Given this list of marker genes COL12A1, CIT, SNX14, EIF4A2, LNPK, CACNA1G, POR, CDH2, KCNK4, KDM4B, HNRNPC, ZFX, NDST1, SFXN4, TMTC3, CRELD1, FNIP1, CTNNA2, TET3, CDC40, SPTBN1, AUTS2, CLCN3, BRPF1, TRAPPC6B, CLP1, DPH2, NFIA, PLAA, CLCN7, PI4KA, PAX3, CARS1, CCNK, ITPR1 (NCBI Gene Id 619543), SIN3A, SEC24D, MINPP1, ASCC3, FDXR, EBF3, WLS, WASHC4, TSEN15, FIG4, CNOT3, TNRC6B, MYT1L, POGZ, CDH11, TRRAP, GRIA1, APC2, TUBB3, KAT8, here is a description of the gene set: species: Homo sapiens Human Gene Set: HP_DELAYED_FINE_MOTOR_DEVELOPMENT A type of motor delay characterized by a delay in acquiring the ability to control the fingers and hands. Delayed fine motor development